The following is a description of a gene set: Mouse Gene Set: GOBP_EXTRACELLULAR_MATRIX_CONSTITUENT_SECRETION studied in species Mus musculus The controlled release of molecules that form the extracellular matrix, including carbohydrates and glycoproteins by a cell., and this is the list of marker genes: Tmem38b, Notch1, Ccn2, Tnfrsf1a, Ier3ip1, Bmp2, Ric1, Cpb2 (NCBI Gene Id 93820), Rgcc, Adtrp, Zfp469, Creb3l1, Tnfrsf1b, Agt, Eng, Prickle1